The following is a description of a gene set: studied in species Homo sapiens The receptor ligand activity of any polypeptide expressed in, and secreted from a neuron. Human Gene Set: GOMF_NEUROPEPTIDE_ACTIVITY, and this is the list of marker genes: AVP (arginine vasopressin), ADCYAP1, PRLH, CALCB, GRP, PENK (NCBI Gene Id 5179), PYY, NPVF, GHRH, OXT, HCRT, PYY3, CCK, CARTPT, UCN, SPX, NPY, CORT, VIP, AGRP, QRFP (pyroglutamylated RFamide peptide), PNOC, CRH, NMB, PPY, VGF, NPFF, GAL, ECRG4, ASIP, NPPA, NTS